Given this list of marker genes GALNT15, MUC6, MUC15, GALNT7, B3GNT6, GCNT1, B4GALT6, GALNT4, MUC16, ST6GALNAC4, GCNT4, GALNT6, MUC3A, GALNT10, MUC4, GALNT3, B3GNT8, GALNT1, MUC13 (NCBI Gene Id 65118), ST3GAL3, MUC12, CHST4, C1GALT1C1, GALNT13, GALNT18, GALNT14, MUC21, MUC17, GCNT7, ST6GAL1, MUC3B, B3GNT7, A4GNT, MUC7, B3GNT3, ST3GAL2, GALNT5, B3GNT9, MUC5B, MUC2, B4GALT5, MUC5AC, GALNT17, B3GNT4, ST6GALNAC2, GCNT3, ST3GAL1, C1GALT1, GALNT2, QTGAL, GALNT11, GALNTL5, B3GNT5, MUCL1, GALNT16 (NCBI Gene Id 57452), GALNTL6, ST6GALNAC3, GALNT9, GALNT12, B3GNT2, MUC19, MUC1, MUC20, GALNT8, ST3GAL4, here is a description of the gene set: Reactome Pathway: O-linked glycosylation of mucins Mucins are a family of high molecular weight, heavily glycosylated proteins (glycoconjugates) produced by epithelial tissues in most metazoa. Mucins' key characteristic is their ability to form gels; therefore they are a key component in most gel-like secretions, serving functions from lubrication to cell signalling to forming chemical barriers. To date, there are approximately genes that express mucins. Mature mucins are composed of two distinct regions:<br>(1) The amino- and carboxy-terminal regions are very lightly glycosylated, but rich in cysteines. The cysteine residues participate in establishing disulfide linkages within and among mucin monomers.<br>(2) A large central region rich in serine, threonine and proline residues called the variable number of tandem repeat (VNTR) region which can become heavily O-glycosylated with hundreds of O-GalNAc glycans.<br> N-acetyl-galactosamine (GalNAc) is the first glycan to be attached, forming the simplest mucin O-glycan. After this, several different pathways are possible generating "core" structures. Four core structures are commonly formed, several others are possible but infrequent. O-linked glycans are often capped by the addition of a sialic acid residue, terminating the addition of any more O-glycans. species: Homo sapiens part of: O-linked glycosylation